Given this list of marker genes Slc25a15, Hnf1a, Slc25a20 (solute carrier family 25 (mitochondrial carnitine/acylcarnitine translocase), member 20), Slc12a2, Slc2a1, Gja1 (NCBI Gene Id 14609), Acsl3, Nr3c1, Slc7a8, Slc26a8 (solute carrier family 26, member 8), Nos2, Kmo, Bdkrb2, Akt1, Slc38a6, Slc16a7, Htr1a, Septin2, Slc43a2, Slco1a1, Repin1, Sv2a, Kcnj8, Slc6a20a, Mpc1, Edn1, Nmur2, Slc51a, Syt4, Apba1, Slco2a1, Fabp7, Slc36a4, Slc11a1, Slc1a3, Slc3a2 (solute carrier family 3 (activators of dibasic and neutral amino acid transport), member 2), Proca1, Ttyh2, Pla2g4a, Abcc5 (NCBI Gene Id 78340), Mfsd2a, Drd3, Nfkbie, Abcb1b, Cyp4a31, Slc22a2, Htr1b, Slc16a3, Drd2 (dopamine receptor D2), Agxt, Fabp6, Slc7a2, Hrh3, Slco1c1, Abat, Slc1a4, Slc17a8, Cacna1a, Fabp5, Slco1a4, Slc26a6 (NCBI Gene Id 171429), Ucp2, Fabp2, Slc25a38, Ces1e, Slc38a7, Slc6a9, Sstr4, Abcc2, Fgf15, Slc17a6, Htr6, Slc26a5, Got2, Slc7a1, Crabp2, Sfxn1, Slc25a1, Snca, Abcg2, Rbp2, Slc16a9, Slc38a1, Slc66a1 (NCBI Gene Id 212555), Abcc10, Slc38a9, Gnat2, Slc35d1, Rgs2, Atp1a3, Slc22a3, Slc25a32, Slc5a8, Lrrc8a, Drd4, Atp5pf, Slc29a4, Il1rn, Plin2, Rbp1, Il1b, Stxbp1, Folr2, Ttyh1, Slco1a7, Tnf (tumor necrosis factor), Cd36, Slc16a10, Slc7a9 (solute carrier family 7 (cationic amino acid transporter, y+ system), member 9), Cacnb4, Acsl5, Slc26a11, Nr0b2, Slc27a4, P2ry2, Slc7a5, Slc6a14, Slco3a1, Pla2g1b, Pparg, Kcnj10, Lrrc8d, Npy5r, Slc27a1, Grm7, Pla2g2e, Lrrc8b, Fis1, Cyp7a1, Slc43a3, Cck, Slc16a14, Pianp, Slc1a7, Slc17a7, Ceacam1, Lypla1, Fxyd1, Cyp4a10, Slc6a7, Rgs4, Slc22a8, Ntsr1, Slc51b, Gfap, Erfe, Slc25a10, Slc7a6 (solute carrier family 7 (cationic amino acid transporter, y+ system), member 6), Ptgs2, Mpc2, Prkcd, Tspo2, Llgl2, Slc1a2, Slc10a3, Rps6kb1, Slco1a5, Rbp7 (NCBI Gene Id 80531), Lrrc8e, Stard10, Mif, Avp, Acsl1, Slco4a1, Pak1, Crot, Grin2b, Agt, Emb, Sfxn2, Cldn2 (NCBI Gene Id 12738), Itgb1, Pnpla8, Grm1, Slc10a6, Prkg1, Slc22a7, Slc16a4, Arl6ip5, Map2k6, Pla2g5, Slc22a6, Cln3, Adora1, Slc6a1, Kiss1r, Ces1g, Pla2r1 (NCBI Gene Id 18779), Oxt, Htr2c, Gabbr1, Lrp2 (NCBI Gene Id 99378, low density lipoprotein receptor-related protein 2), Thbs1, Arl6ip1, Slc38a2, Slc27a5, Per2, Slc7a4, Slc10a4-ps, Apoe, Slc32a1, Syk, Avpr1a, Akt2, Vps54, Slc25a22, Slc10a4, Nf1, Avpr1b, Slc1a5, Adora2a (adenosine A2a receptor), Slc19a1, Slc16a6, Ces1c, Slco1b2, Slc25a12, Slc26a7, Nr1h4, Slc6a8, Myo6, Slc10a7, Slc27a2, Slc27a6, Slc25a2, Slc22a13, Fabp4, Slc16a11, Kcnk1, Nfe2l1, Slc38a5, Psen1, Slc25a21, Slc43a1, Slco2b1, Ppard, Pla2g2d, Slc6a6, Slc25a44, Slc5a6, Fabp12, Slc26a1, Pla2g2a, Agtr2, Slc36a2, Gipc1, Dtnbp1, Ces1a, Hrh2, Slc25a29, Cpt1b, Slc3a1, Pla2g12a, Slc17a5, Slc25a26, Slc27a3, Slc25a13, P2rx7, Slc6a15 (solute carrier family 6 (neurotransmitter transporter), member 15), Kcnk2, Folr1, Anxa1, Abcb1a, Slc6a5, Sfxn3, Myc (NCBI Gene Id 17869), Slc13a2, Aqp8 (NCBI Gene Id 11833), Mapk9 (NCBI Gene Id 26420), Slco1a8, Slc16a8, Abcd3 (ATP-binding cassette, sub-family D member 3), Slc10a2, Slc47a1, Trh, Slc7a7, Slc7a3, Mfsd12, Slc46a1, Oc90, Slc6a20b, Nmb, Best1, Abcc8, Mip, Slc15a4, Rab3gap1, Slc16a1, Casr (calcium-sensing receptor), Cpt2, Lhcgr, Trpv1, Pla2g6, Pla2g3, Abcd2, Slc22a22, Slc25a11, Nherf1, Acacb, Slc25a18, Pdpn (NCBI Gene Id 14726), Slc23a1, Pla2g12b, Slc1a1, Fabp1, Ces1f, Slc36a1, Ces1b, Slc36a3, Slc38a4, Abcb11, Slc7a13, Slco1a6, Trpc4 (transient receptor potential cation channel, subfamily C, member 4), Abcb4, Acsl4, Arg2, Ceacam2, Slc10a1, Slc25a17, Selenon, Fabp9, Atp8b1, Lyn, Slc22a1, Cyp4a32, Slc6a13, Abcc3, Cln8 (CLN8 transmembrane ER and ERGIC protein), Slc1a6, Psap, Bdnf, Slc5a12, Sfxn5, Pla2g4f, Slc13a5, Abcc6, Slc23a2, Pla2g2f, Cltrn, Abcc4, Abcd4, Lrrc8c, Abcd1, Crabp1, Grm2, Ntrk2, Pla2g10, Slc13a3 (solute carrier family 13 (sodium-dependent dicarboxylate transporter), member 3), Slc38a3, Slc6a12, Ctns, Il1a, Slc7a14, Lep, Epm2a, Grik1, Spx, Slc7a10, Irs2, Slc16a12, Arhgef11, Ace2, Aqp9 (aquaporin 9), Ttyh3, Tnfrsf11a, Abcc1, Eprs1, Dpysl2, Slc19a3, Tnfsf11, Ces1h, Pmp2, Umod, Ces1d, Arg1, Pla2g2c, Slc6a11, Ace, Tmem135, Fabp3 (fatty acid binding protein 3, muscle and heart), Ptges, Nat3, Slc6a17, Slc7a11, Slc10a5, Acsl6, here is a description of the gene set: species: Mus musculus The directed movement of organic acids, any acidic compound containing carbon in covalent linkage, into, out of or within a cell, or between cells, by means of some agent such as a transporter or pore. Mouse Gene Set: GOBP_ORGANIC_ACID_TRANSPORT